The following is a description of a gene set: Genes in cluster 4: immediate down-regulation in HFW cells (fibroblast) by sodium arsenite. Human Gene Set: YIH_RESPONSE_TO_ARSENITE_C4 from publication Yih LH, Peck K, Lee TC (PMID 12016162) Arsenic compounds are widely distributed and arsenic ingestion is associated with many human diseases, including blackfoot disease, atherosclerosis, and cancers. However, the underlying mechanism of arsenic toxicity is not understood. In human fibroblast cells (HFW), arsenite is known to induce oxidative damage, chromosome aberrations, cell cycle arrest, and aneuploidy, and the manifestation of these cellular responses is dependent on changes in gene expression which can be analyzed using the cDNA microarray technique. In this study, cDNA microarray membranes with 568 human genes were used to examine mRNA profile changes in HFW cells treated for 0 to 24 h with 5 microM sodium arsenite. On the basis of the mean value for three independent experiments, 133 target genes were selected for a 2 x 3 self-organizing map cluster analysis; 94 were found to be induced by arsenite treatment, whereas 39 were repressed. These genes were categorized as signal transduction, transcriptional regulation, cell cycle control, stress responses, proteolytic enzymes, and miscellaneous. Significant changes in the signaling-related and transcriptional regulation genes indicated that arsenite induces complex toxicopathological injury. studied in species Homo sapiens, and this is the list of marker genes: NPAT, NCK1, MYCN, EGFR, CDC42, F11R, CXCL8, NR2F6, KRT8, ELK1, ETV6, JUN, CRADD, TAPBP, EIF4E, GRB2, RAB3A